Given this list of marker genes CAV1, NR1H3, PROM2, STX1B, NR1H2, here is a description of the gene set: Human Gene Set: GOBP_NEGATIVE_REGULATION_OF_PINOCYTOSIS Any process that stops, prevents, or reduces the frequency, rate or extent of pinocytosis. Pinocytosis is the process in which cells take in liquid material from their external environment; literally 'cell drinking'. Liquid is enclosed in vesicles, formed by invagination of the plasma membrane. These vesicles then move into the cell and pass their contents to endosomes. species: Homo sapiens